The following is a description of a gene set: Human Gene Set: GSE2770_IL12_ACT_VS_ACT_CD4_TCELL_2H_DN Th1 and Th2 cells arise from a common precursor cell in response to triggering through the TCR and cytokine receptors for IL-12 or IL-4. This leads to activation of complex signaling pathways, which are not known in detail. Disturbances in the balance between type 1 and type 2 responses can lead to certain immune-mediated diseases. Thus, it is important to understand how Th1 and Th2 cells are generated. To clarify the mechanisms as to how IL-12 and IL-4 induce Th1 and Th2 differentiation and how TGF-beta can inhibit this process, we have used oligonucleotide arrays to examine the early polarization of Th1 and Th2 cells in the presence and absence of TGF-beta after 0, 2, 6 and 48 hours of polarization. from publication Lund R, Aittokallio T, Nevalainen O, Lahesmaa R (PMID 14607935) studied in species Homo sapiens Genes down-regulated in CD4 T cells activated by anti-CD3 and anti-CD28: IL-12 (2h) versus untreated (2h)., and this is the list of marker genes: STX3, CCRL2, PLPP5, INO80C, RAB7A, HPD, PHF13 (NCBI Gene Id 148479), TUBB4B, MGLL, GSR, NEU1, KYNU, TPRA1, PJA1, MSC, UXS1, CTNND1, HEG1, TRIO, FGGY, MIR3142HG, IPO9, ANKRD12, SC5D, ZNFX1, TOP1 (DNA topoisomerase I), SWT1, ZFP3, PDGFA, FADD, TMEM51, PPP4C, DGKH, PAFAH1B1, ZFYVE1, SLC41A2, GTF2A1, CD40, GSTO1, KANSL3, SIRPA, NMT2 (N-myristoyltransferase 2), RAB1A, YAE1, BTBD7, BSDC1, TMEM199, TM2D2, AMPD3, TWSG1, ALCAM, PLEKHB2, PSMC1, LGMN, ITGA5, MOB3C, LMAN2L, C1orf122, GABARAPL2, BANP, H2AC16, ST3GAL2, NPC1, PDCD6IP (NCBI Gene Id 245794), MTCH2, PTGR1, FEN1, SLC1A3, DERL2, SQOR, PSMC4, GPATCH3, SLC9B2, ABCC1, PSMD1, CEMIP2, RBM23, RAB3GAP1, ZNF274, PIK3R5, STK17A, BTG3, TANK, CAMSAP2, OSBPL11, CTSB, MYO1B, TRIM21, TRAF3, ARFGAP3 (ADP ribosylation factor GTPase activating protein 3), MLLT6, SERAC1 (serine active site containing 1), RAD54L2, PIM3, ITGB8, CHMP2B, ATP6V0E1, PNPLA1, JAKMIP2, ITGB3, CALU, ANAPC7, ATP13A3-DT (ATP13A3 divergent transcript), ATP6V1C1 (NCBI Gene Id 528), CCR5, ADAM17, KBTBD4, ITPRIPL2, ZNF200, ZNF691, DNAJB6 (DnaJ heat shock protein family (Hsp40) member B6), MDC1, EREG, PSEN1, CD82, IL1B, CES1, TMCO3, DYNLL1, PSMA3, SLC38A7, KCNN4, CTNS, C3, ZMIZ1-AS1, PPP1R10, TDP2 (NCBI Gene Id 51567), EML4, SERPINB8, YRDC (yrdC N6-threonylcarbamoyltransferase domain containing), DNAJA1, SOWAHC, TSC22D1, MAMLD1, SPINK1, SQLE, PTPN12, KMO, CLTC, MSMO1, LINC01936, CREG1, MED13, IL1A, UBL5, TMEM138, ZBTB6, TXLNA, AREL1, MED31, YIPF6, SFT2D2, CFLAR, NFE2L2, WSB2, ITGB1, ZC3H12C, PSMD11, ZSCAN32, FAF2, HIVEP2, NMRAL2P, TUBB6, APBA3, UBE2A, ZER1, GON4L, PRPS1L1, PDXK, CD58, MTG2, SLC5A3, TUBD1, NFAT5, ATP6V1B2, CYP51A1, DYNC1H1, H2BC3, VPS33A, DAB2, ZNF557, IGF2R, JPT2, TSG101, DYDC2, STARD3NL, CRIM1, RGL2, KIF1B, TMEM214, FADS3, MRPS31, RNF13, CRNKL1, MREG, EYA3, USP9X, HK2, RNF185 (ring finger protein 185), HSPA8